The following is a description of a gene set: species: Mus musculus Catalysis of the reaction: acetyl-CoA + a L-amino acid = CoA + an N-acetyl-L-amino-acid. In some cases acetyl phosphate can be used as a donor. Mouse Gene Set: GOMF_L_AMINO_ACID_N_ACETYLTRANSFERASE_ACTIVITY, and this is the list of marker genes: Nat8f4, Atat1, Ep300, Nat8f7, Nat8f1, Kat2b, Nat8l, Nat8f6, Esco2, Nat8, Nat8f2, Nat8f3, Nags, Nat8b-ps, Nat8f5